Given this list of marker genes LMNB2, FXR1, NDC1 (NCBI Gene Id 55706), LMNA, LMNB1, here is a description of the gene set: Human Gene Set: GOBP_NUCLEAR_PORE_LOCALIZATION species: Homo sapiens Any process in which nuclear pores are transported to, or maintained in, a specific location.